Given this list of marker genes PQBP1, CHSY1, NOG, GDF5, ROR2, NONO, BHLHA9, PTDSS1, here is a description of the gene set: Proximal symphalangism of hands Human Gene Set: HP_PROXIMAL_SYMPHALANGISM_OF_HANDS studied in species Homo sapiens The term proximal symphalangism refers to a bony fusion of the middle and proximal phalanges of the digits of the hand, in other words the proximal interphalangeal joint (PIJ) is missing which can be seen either on x-rays or as an absence of the proximal interphalangeal finger creases.